The following is a description of a gene set: Mouse Gene Set: GOBP_PYRIMIDINE_RIBONUCLEOSIDE_MONOPHOSPHATE_METABOLIC_PROCESS studied in species Mus musculus The chemical reactions and pathways involving pyrimidine ribonucleoside monophosphate, a compound consisting of a pyrimidine base linked to a ribose sugar esterified with phosphate on the sugar., and this is the list of marker genes: Dhodh, Cda, Nt5c3, Upb1, Upp1, Dpyd, Umps, Dck, Nt5c, Cad, Uckl1, Uck1, Uck2, Upp2, Dpys, Uprt (NCBI Gene Id 331487)